Given this list of marker genes PDPN, APC, FGF8, TMEM216, POU1F1, CSPP1, MEIS2, ITGA8, EBP, FOXP2, FOCAD, SMC1A, TMEM107, EXOSC2, RMRP, IL2RA, ARSL, BMPER, KDM6A, ALX4, PLK4, TRAF6, COL1A1, SAMHD1, TMEM67 (NCBI Gene Id 91147), TBL1XR1, DMXL2, CASZ1, GJA1, IGF1, EP300, SPEN, BUB1B (NCBI Gene Id 701), UBE4B, FOXA2, EDAR, PKHD1, KDF1 (keratinocyte differentiation factor 1), CAV1, PLAAT3, CENPE, MAN2B1, GRIP1, NIPBL, HDAC6, EFEMP2, B9D1, BUB3, NHEJ1 (non-homologous end joining factor 1), SUZ12, LSM11, CRIPTO (NCBI Gene Id 6997), ANTXR1, STAT5B, RNASEH2A, EDA, DNA2, PEX12, MYH3, DDR2, ADAT3, LUZP1, NRAS, IL11RA, CDON, RLIM, NFKBIA, LHX4, LTBP1, SOST, PAX7, RNU7-1, PRPS1, TRIP13, GLI2, ELN, PLCH1, COG4, ATP6V1E1, ATRX, FGF20, CENPT, LIG4, MMP23B, RNASEH2B, FGFRL1, FGFR3, ERF (NCBI Gene Id 2077), GLB1, BMP4, PHGDH, CSGALNACT1, CCDC22, FGFR2, UBR1, MN1, TBCE, LEMD2, PUS1 (NCBI Gene Id 80324), NUP85, VPS13B, TFAP2B, HNRNPH1, BUB1, PTF1A (NCBI Gene Id 256297), TWIST2, LMNA, PROP1, RAB23, MGAT2, KMT2D, RERE, CHD6, ATRIP, EDARADD, ZEB2, C12orf57, PTPN11, PPP2R3C, RET, RPL10, SATB2, HSPG2, JAG1, MEGF8, GABRD, PSAT1, CEP290, HESX1, ASPH (aspartate beta-hydroxylase, NCBI Gene Id 56921), ZPR1, TRAIP, EDA2R, AP4M1, TREX1, WRN, PEPD, ALDH18A1, ERCC2, FBXL4, LETM1 (NCBI Gene Id 3954), SIX3, PIGL, RUNX2, SMARCA2, SOX3, SLC2A10, NODAL, TCTN1, WDR73, SHANK3, SLC37A4, SNAP29, ALG9 (ALG9 alpha-1,2-mannosyltransferase), ITCH, STIL, ADAR (NCBI Gene Id 3427), CTBP1, NUP188, ATR, NALCN, STAG2, DISP1, SKIC3, TBX1, CHRNG, DPF2, SLC25A24, OTX2, CANT1, PRDM16, RPGRIP1, ZIC2, NSD2, FOXH1, CNOT3, SCARF2, FOXC1 (forkhead box C1), RECQL, TWIST1, ZMPSTE24, AASS, FBXO11, CLCN3, LRP4, FAM20C, HSPA9, RPS19, PRMT7, TCTN2, HRAS (NCBI Gene Id 338029), LMBR1, ABCA12, TXNDC15, SHH, SLC35C1, ERCC4, PRKCZ, KCNAB2, NEK9, POLR3A, TMEM237, GREB1L, ATP7A, CEP55, PTCH1, CEP57, COL3A1, RNASEH2C, RBBP8, TMEM231, TGIF1, PRKAR1A, WNT9B, MBD5, COL1A2, CC2D2A (NCBI Gene Id 57545), BANF1, PYCR1, XRCC4, DZIP1L, PAX3, DONSON, METTL5, TAF4, MTX2, MKS1, B9D2, SOX9, CREBBP, FBN1, ASH1L, CTSK, GH1, EFNB1, TCTN3, FGFR1, RECQL4 (NCBI Gene Id 9401), GHR, MBTPS2, GAS1, CPLX1, DLL1, CHRNA1, HNRNPK, IFIH1, CHRND, MSL3 (MSL complex subunit 3), NBN, GMNN, GFRA1 (NCBI Gene Id 2674), POLD1, RPGRIP1L, PDE4D, PCNT (NCBI Gene Id 9346), SKI, LBR, PEX1, CEP152, PDGFRB, GLI3, here is a description of the gene set: studied in species Homo sapiens Abnormal nasal dorsum morphology Human Gene Set: HP_ABNORMAL_NASAL_DORSUM_MORPHOLOGY An abnormality of the nasal dorsum, also known as the nasal ridge.